Given this list of marker genes GOT2, RDX, GTF3A, ZFYVE26, PSMA2, EIF3B, PPM1G, SNRPD1, CKM, INPPL1, TRAP1, MOGS, FARSA, H4C3, BRWD1, IGFBP2, SRL, RANBP1, COX6A2, FAM8A1 (NCBI Gene Id 51439), TNNI1, PTEN, PSMD1, CSE1L, TOP2A, UCK2, RB1, ERBB3, MYOG, MYH3, GLUL, NDUFB2, NUP93, MYC, PIK3R1, C1QBP, FARSB, GSPT1, SORD, QDPR (quinoid dihydropteridine reductase), MTHFD1, SDHA, SNRPA1, EIF2S2, TSC1, TRIP12, DHX15, HBZ (NCBI Gene Id 3050), TNNC1, FKBP5, MTOR, here is a description of the gene set: Breast cancer outcome is highly variable. Whether inadvertent exposure to environmental xenobiotics evokes a biological response promoting cancer aggressiveness and a higher probability of tumor recurrence remains unknown. To determine specific molecular alterations which arise in high-risk breast tissue in the presence of the ubiquitous xenoestrogen, bisphenol A (BPA), we used nonmalignant random periareolar fine-needle aspirates in a novel functional assay. Early events induced by BPA in epithelial-stromal cocultures derived from the contralateral tissue of patients with breast cancer included gene expression patterns which facilitate apoptosis evasion, endurance of microenvironmental stress, and cell cycle deregulation without a detectable increase in cell numbers. This BPA response profile was significantly associated with breast tumors characterized by high histologic grade (P < 0.001) and large tumor size (P = 0.002), resulting in decreased recurrence-free patient survival (P < 0.001). Our assays show a biological fingerprint of probable prior exposure to endocrine-disrupting agents, and suggest a scenario in which their presence in the microenvironmental milieu of high-risk breast tissue could play a deterministic role in establishing and maintaining tumor aggressiveness and poor patient outcome. studied in species Homo sapiens from publication Dairkee SH, Seok J, Champion S, Sayeed A, Mindrinos M, Xiao W, Davis RW, Goodson WH (PMID 18381411) Human Gene Set: DAIRKEE_CANCER_PRONE_RESPONSE_BPA 'Cancer prone response profile' (CPRP): genes changed in response to bisphenol A in epithelial cell cultures from patients at high risk of breast cancer.